The following is a description of a gene set: Strongly up-regulated at 8 h during differentiation of 3T3-L1 cells (fibroblast) into adipocytes. During cellular differentiation and development, it is recognized that many complex molecular mechanisms as well as precise patterns of differentially expressed genes occur in directing precursor cells toward a given lineage. Using microarray-based technology, we examined gene expression across the course of 3T3-L1 adipocyte differentiation. Total cellular RNA was isolated at times 0, 2, 8, 16, 24, 48, and 96 h following treatment with either standard hormonal inducers of differentiation; insulin, dexamethasone, isobutylmethylxanthine (IDX), or IDX plus trichostatin A (TsA), a histone deacetylase inhibitor and potent adipogenic inhibitor. cRNA was synthesized from cellular RNA and hybridized to high density Affymetrix MG_U74Av2 microarray gene chips containing 12,488 cDNA/Expressed Sequence Tags (ESTs) probe sets. From the IDX-only treated cells, all probe sets that were either unchanged or differentially expressed less than 2-fold throughout differentiation with respect to time 0 preadipocytes were excluded from further analyses. This selection resulted in a net of 1686 transcripts, 859 were increased in expression, and 827 were decreased in expression at least 2-fold across differentiation. To focus in on genes that were more specific to differentiation, the same analysis was performed on IDX plus TsA-treated non-differentiating cells and all probe sets from the IDX-only group that exhibited similar expression profiles in the non-differentiating TsA-treated group were excluded leaving a total of 1016 transcripts that were regulated only under differentiating conditions. Six hundred and thirty-six of these transcripts were elevated at least 2-fold and 380 exhibited a decrease in expression relative to time 0 preadipocytes. This group of genes was further analyzed using hierarchical clustering and self-organizing maps and resulted in the identification of numerous genes not previously known to be regulated during adipocyte differentiation. Many of these genes may well represent novel adipogenic mediators and markers of adipogenesis. from publication Burton GR, Nagarajan R, Peterson CA, McGehee RE Jr (PMID 15033539) studied in species Mus musculus Mouse Gene Set: BURTON_ADIPOGENESIS_2, and this is the list of marker genes: Tgfbr3, Sdc1, Kcnn4, Bop1, Fkbp5, Rhoj, Srxn1, Rasa3, Prr5, Map3k6, Spsb1, Timp1, Ptges, Krt13 (keratin 13), Ank3, Lxn, Avpi1, Slc7a6, Mcl1, Hspd1, Ugdh, Ctla2a, Gnptab, Per2, Samhd1, Bcat1, Pa2g4, Gm5364, Gsto1, Fst, Fosl1, Rhou, Tpm4, Sphk1, Grwd1, Ramp3, Prdx6, Limk1, Slc6a6, Nf2, Cad, Il1rl1, Sar1b, Tll1, Il1r1, Col4a1, Nsun2, Hmga2, Gja1, Pgd, Sash1, Srm, Sfpq, Clic4, Mknk2, Xdh, Tle1, Tubb3, Ccnd3, Ivns1abp, Serp1, Vdr, Ftsj3, St3gal1, Rbm14, Prkce, Srr, Nop56, Itga5, Sidt2, Hsph1, Tead4, Snai1